The following is a description of a gene set: Binding to flavin mono nucleotide. Flavin mono nucleotide (FMN) is the coenzyme or the prosthetic group of various flavoprotein oxidoreductase enzymes. studied in species Homo sapiens Human Gene Set: GOMF_FMN_BINDING, and this is the list of marker genes: PNPO, NDUFV1, NDOR1, TYW1, HAO2, TYW1B, POR, NOS2, HAO1, NOS1, PPCDC (NCBI Gene Id 60490), NOS3, IYD, DUS2, MTRR